The following is a description of a gene set: Mouse Gene Set: GOBP_POSITIVE_REGULATION_OF_PROTEIN_CONTAINING_COMPLEX_ASSEMBLY Any process that activates or increases the frequency, rate or extent of protein complex assembly. studied in species Mus musculus, and this is the list of marker genes: Nckap1l, Arhgef5, Terf1, Cdk5rap2, Zdhhc1, Ifng, Sh3glb1, Dab2ip, Ice1, Bax, Nrg1, Stmp1, Usp50, Baiap2, Mapk9, Hip1r, Carmil2, Wnt10b, Nphs1, Plcg2, Fnip2, Lmod2, Fes, Rhoc, Brk1, Snx9, Alox15, Clu, Prkd1 (protein kinase D1), Rictor, Nav3, Nr1h2, Prkce, Pak1, Mmp3, Gda, Tppp, Csf3, Casp4, Ptpn22, Syk, Foxc2, Ahr, Dctn1, Ccl21d, Gm12250, Cxcl13, Dlg1, Psmc6, Snca, Lats1, Apc, Rap1b, Tal1, Ccl21a, Snap91, Ckap5, Mark4, Hrk (NCBI Gene Id 12123), Med25, Creb1, Fermt1, Btk, Lcp1, Cdh5, Clec7a, Mecp2, Arl2, Ptk2b, Fas, Hsp90aa1, Caly, Akap9, Slf1, Trim65 (tripartite motif-containing 65), Tppp3, Fnip1, Cdc42ep4, Cttn, Nek7, Atm, Atr, Cracd, Eif4g1, Git1, Actr3, Il5, Ccl21e, Rack1, Tppp2, Tlr4, Gbp5, Myd88, Brcc3dc, Baiap2l2, Tnf, Tenm1, Abca3, Bak1, Cav3, Arpc2, Cdc42ep1, Msn, Bik, Gbp2, Hspa1a, Arf6, Bag4, Ajuba, Ttbk1, Slain1, Cdkn1b, Vegfa, Tfrc, Ppp2r5b, Skap1, Stub1, Numa1, Plek, Cd36, Rasip1, Bin1, Gsk3b, Ccl21b, Rac1, Faf1, Ddx3x, Lmod1, Atat1, Drg1, Map1b, Clip1 (CAP-GLY domain containing linker protein 1), Trabd2b, Trp53, Cdc42ep3, Pfn1, Mlst8, Fermt2, P2ry12, Rhoa, Epn1, Cd24a (CD24a antigen), Cav1, Cand1, Bid, Rims1, Ppp2ca, Park7, Fmn1, Lats2 (NCBI Gene Id 50523), Lgals3, Gnl3l, Gm14137 (predicted gene 14137), Mapre1, Cdc42ep2, Nck1, Brcc3, Hspa1b, Mapt, Csf2, Vasp, Ccl21f, Ikzf1, Cdc42ep5, Pcsk5, Togaram1, Unc13b, Mmp1b, Mpp7, Src, Ambra1, Fer, Psrc1, Bbc3, Icam1, Map3k1, Crbn, Mapk8, Wars1, Fchsd1 (NCBI Gene Id 319262), Sumo1, Fchsd2, Tlr6, Pycard, Dhx33, Ccl24, Isg15, Bmf, Rps3, Myo1c, Evl, Grb2, Baiap2l1, Mmp1a, P2rx7 (purinergic receptor P2X, ligand-gated ion channel, 7), Zdhhc5, Bcl2l11, Nck2, Slf2, Cck, Pfn2, Cdh17, Hdac6, Kirrel1, Carmil1, Mtln (mitoregulin), Slain2, Ccl26, Mtor, Tgfb1, Met, Piezo1, Pde4dip, Abca1, Mavs, Spidr, Nckap1, Tirap, Ccl11, Fscn1, Vcp, Trhr, Ankrd53